The following is a description of a gene set: The chemical reactions and pathways involving compounds that contain an indole (2,3-benzopyrrole) skeleton. species: Mus musculus Mouse Gene Set: GOBP_INDOLE_CONTAINING_COMPOUND_METABOLIC_PROCESS, and this is the list of marker genes: Il4i1, Afmid, Maoa, Asmt, Acmsd, Haao, Tdo2 (NCBI Gene Id 99471), Nmnat2, Tph1, Nadsyn1, Ido2 (NCBI Gene Id 209176), Qprt, Ddc, Grin2a, Fev, Btbd9, Atp2b2, Kynu (kynureninase), Pde1b, Aldh2, Ido1 (NCBI Gene Id 15930), Aanat, Cyp2d22, Kmo, Tph2, Mdga1, Rnf180, Htr1a (5-hydroxytryptamine (serotonin) receptor 1A), Atp7a, Gch1, Spr, Gcdh (glutaryl-Coenzyme A dehydrogenase)